Given this list of marker genes NDFIP1, STC1, CPEB2, RBM20, NRBP2, ADAM12, FAM114A2, HIPK1, TSSK1B, FAM78A, SCN3B, MTMR4, MECP2, TUSC3, CMC4, PCDHB6, FAM169BP, RAB1A, SHISA6, CCL11, ZNF589, KPNA3, CXorf38, KRTAP9-4, COPS2, SERPINE3, KRTAP9-2, TLCD3A, OR12D3, SFXN3 (NCBI Gene Id 94083), CFLAR, SST, CHRDL1, TMEM106A, FSCN3, PDE6D, BCAM, MFHAS1, OR2H1, TM4SF19 (transmembrane 4 L six family member 19), ZSCAN16, IRAK1BP1, MAOB, LHPP, KRTAP9-8 (keratin associated protein 9-8), GPATCH1, ZNF784, here is a description of the gene set: Human Gene Set: MIR6894_5P Genes predicted to be targets of miRBase v22 microRNA hsa-miR-6894-5p in miRDB v6.0 with MirTarget v4 prediction scores > 80 (high confidence targets). studied in species Homo sapiens from publication Chen Y, Wang X (PMID 31504780)